The following is a description of a gene set: Oxidized phospholipids are thought to promote atherogenesis by stimulating endothelial cells (ECs) to produce inflammatory cytokines, such as IL-8. In studies with mouse models, we previously demonstrated that genetic variation in inflammatory responses of endothelial cells to oxidized lipids contributes importantly to atherosclerosis susceptibility. We now show that similar variations occur in cultured aortic ECs derived from multiple heart transplant donors. These variations were stably maintained between passages and, thus, reflect either genetic or epigenetic regulatory differences. Expression array analysis of aortic EC cultures derived from 12 individuals revealed that >genes were regulated by oxidized phospholipids. We have used the observed variations in the sampled population to construct a gene coexpression network comprised of 15 modules of highly connected genes. We show that several identified modules are significantly enriched in genes for known pathways and confirm a module enriched for unfolded protein response (UPR) genes using siRNA and the UPR inducer tunicamycin. On the basis of the constructed network, we predicted that a gene of unknown function (MGC4504) present in the UPR module is a target for UPR transcriptional activator ATF4. Our data also indicate that IL-8 is present in the UPR module and is regulated, in part, by the UPR. We validate these by using siRNA. In conclusion, we show that interindividual variability can be used to group genes into pathways and predict gene-gene regulatory relationships, thus identifying targets potentially involved in susceptibility to common diseases such as atherosclerosis. from publication Gargalovic PS, Imura M, Zhang B, Gharavi NM, Clark MJ, Pagnon J, Yang WP, He A, Truong A, Patel S, Nelson SF, Horvath S, Berliner JA, Kirchgessner TG, Lusis AJ (PMID 16912112) Human Gene Set: GARGALOVIC_RESPONSE_TO_OXIDIZED_PHOSPHOLIPIDS_PURPLE_DN studied in species Homo sapiens Genes from the purple module which are dn-regulated in HAEC cells (primary aortic endothelium) after exposure to the oxidized 1-palmitoyl-2-arachidonyl-sn-3-glycerophosphorylcholine (oxPAPC)., and this is the list of marker genes: IFFO1, RALGAPA2, MOV10L1, CCDC18-AS1, STAT1, ADAMTS6, MTUS1, FOXP1, ANAPC5, GAS5, LAMB1, RBMX (RNA binding motif protein X-linked), PRAG1